Given this list of marker genes Fgf21, Ttc39a, Ctdspl, Hs3st3b1, Zzef1, Zfp689, Fgfr3, Nox4, Baz2a, Ptgir, Ap1ar, Seh1l, Hs3st2, Mtor, Smarca5, Kbtbd8, here is a description of the gene set: from publication Chen Y, Wang X (PMID 31504780) Genes predicted to be targets of miRBase v22 microRNA mmu_miR_99b_5p in miRDB v6.0 with MirTarget v4 prediction scores > 80 (high confidence targets). studied in species Mus musculus Mouse Gene Set: MIR_99B_5P